The following is a description of a gene set: species: Homo sapiens The series of events required for an organism to receive an orientational stimulus, convert it to a molecular signal, and recognize and characterize the signal. Equilibrioception refers to a combination of processes by which an organism can perceive its orientation with respect to gravity. In animals, stimuli come from labyrinth system of the inner ears, monitoring the direction of motion; visual stimuli, with information on orientation and motion; pressure receptors, which tell the organism which body surfaces are in contact with the ground; and proprioceptive cues, which report which parts of the body are in motion. Human Gene Set: GOBP_EQUILIBRIOCEPTION, and this is the list of marker genes: CDH23, USH1C, CLRN1, ANKFN1, MYO7A, USH1G, POU4F1, PCDH15